Given this list of marker genes OSTN, GNAS, MAG, G6PD, EPHA7, CDKN1A, PTCH1, RNF6, SLIT1, CDK5, STK4, CAV3, MAPK11, TLL2, FXN, RYK, WNT5A, SEMA3F, VGLL4, STK3, MIR17HG, SAV1, CDH1, MIR873, MIR1-1, FGFR3, WNT3, RGS4, PTPRS, ULK2, MAP2, TRIM46, PLXNA3, MIR200B, ADRB3, CTDP1, CGA, WWC3, PI16, ARHGAP4, WWC1, SOCS2, RTN4, HDAC6, DCC, SPAG9, NOG, TNR, SEMA4F, MYOZ1 (myozenin 1), RGS2, CDKN1B (cyclin dependent kinase inhibitor 1B), RGMA, RBP4, GDF15, TBX5, NTN1, CDKL3, SPP1, ATG16L1, SEMA3G, PAK1, ADRB2, SEMA6C, TP73, SEMA6D, PLAC8, RTN4R (reticulon 4 receptor), PTEN, MIR199B, KIAA0319, FSTL4, KCNK2, PPARA, JARID2, SPART, LGMN, YY1, GSK3A, BCL11A, ULK1, MIR25, DUSP10, ADRB1, MIR199A1, IFRD1, SLC6A4, MSTN, DRAXIN (NCBI Gene Id 374946), FOXP1, WWC2, WNT3A, BBS2 (NCBI Gene Id 583), DIP2B, SEMA5A, TOMM70, MT3, FGF13, CFL1, NRP1, STC2, RAI1, here is a description of the gene set: Human Gene Set: GOBP_NEGATIVE_REGULATION_OF_DEVELOPMENTAL_GROWTH Any process that stops, prevents, or reduces the frequency, rate or extent of developmental growth. studied in species Homo sapiens